The following is a description of a gene set: Any process that activates or increases the frequency, rate or extent of protein K63-linked ubiquitination. Mouse Gene Set: GOBP_POSITIVE_REGULATION_OF_PROTEIN_K63_LINKED_UBIQUITINATION studied in species Mus musculus, and this is the list of marker genes: Ube2n, Ptpn22, Ripk2, Ddx3x, Ube2v2, Ube2v1, Nod2, D1Pas1, Birc2